Given this list of marker genes ADIPOR1, STK11, PRKAB2, PRKAA2, ADIPOR2, PRKAG2, ADIPOQ, MLXIPL, here is a description of the gene set: AMPK inhibits chREBP transcriptional activation activity Human Gene Set: REACTOME_AMPK_INHIBITS_CHREBP_TRANSCRIPTIONAL_ACTIVATION_ACTIVITY species: Homo sapiens